The following is a description of a gene set: Human Gene Set: GSE37301_MULTIPOTENT_PROGENITOR_VS_GRAN_MONO_PROGENITOR_UP studied in species Homo sapiens Expression profiling of Rag2-deficient Ets1++ and Rag2-deficient Ets1-- mature NK cells and WT bone marrow progenitors, WT T cells, and WT Pro B cells from publication Ramirez K, Chandler KJ, Spaulding C, Zandi S, Sigvardsson M, Graves BJ, Kee BL (PMID 22608498) Genes up-regulated in multipotent progenitors versus granulocyte-monocyte progenitors., and this is the list of marker genes: GLI3, DNTTIP2, PAK3, ZNF574, ZZZ3, CXCL2, TBL2, TPD52 (NCBI Gene Id 7163), GBP7, APOA5, MYD88 (NCBI Gene Id 4615), PRKAB1, CGA, SETDB1, CEBPD, KLF2, MAPKAPK5, FBXL12, TOR3A, RACK1, CDCP1, SNX10, RNASE3, SLC6A8, PSME1, SEMA6B, MYL6B, CCDC86, MTHFD2, FGFR3, SELENOW, NELFA, PSMB8, PDK3, ABRACL, TYR, PKM, ZNF639, CD244, HELB, SYCP3, BET1L, POU3F3, NIPBL, STC1, C16orf89, CTNNA1, IL10RB, MYH4, MAF, CR2, HPX, ADIPOQ, INTS9, GNL3, HMGA2, LRP10, C11orf16, ID1, SRRM1, DAB2, FANCG, COL13A1, NREP, POLA1, MFSD4A, CASP8AP2, MAP4K3, C5AR1, GRINA, GPR12, PRDM5, UBE2S, DDX39B, CYB561, NAMPT, GATA2, NIP7 (nucleolar pre-rRNA processing protein NIP7), TNFRSF1A, IL17RA, NOP58, IRGM, CD14, IFIH1, XDH, PLSCR1, CAMLG, LEPROT, IGLL1, TCIRG1, EXT1 (NCBI Gene Id 3966), IL13RA1, INTS6, ADAM9, KRT34, BZW2, ROM1, PTPN1, JAK2, RSAD2, IDNK (IDNK gluconokinase), HOXC6, IFIT2, PKDCC, KLRD1, AZIN1, CDH3, CD2BP2, PGM2, PRSS58, NGDN, SLC1A5, HOXC5, IL7R (NCBI Gene Id 3575), C5orf15, RFX1 (regulatory factor X1), ABCB10, COL4A1, FXYD7, ACTN2, TUT7, SENP3, LMO4, MVP, FOXO4, KRR1, KL, H3-5, SAMD4B, MYBPH, MX2, ISG15, CMPK2, WDR26, LMNB2, MC3R, GNA14, MSH2, MAP2K1, STAT1, CD34, SLC6A1, BLK, KRTAP8-1, SHISA5, ALK, NUB1, PPAN, PDCD7, PGAP4, ISG20 (interferon stimulated exonuclease gene 20), MDN1, EFNA1, PML, UTP3, F2RL2, EIF3F, SAMHD1 (SAM and HD domain containing deoxynucleoside triphosphate triphosphohydrolase 1), NKX2-2 (NCBI Gene Id 4821), BMP2K, USP18, PHC2, PI4K2A, RAB3IP, UCK2, ANXA2, PTPN2, REEP1, ACKR3, TRDMT1, SCN10A, EPS8, LY75 (NCBI Gene Id 4065), SSX2IP, EXTL3, MPL, PLAGL1, ANPEP, GEMIN5, BCL3, HLA-G, SOD2, PRG3, IFNA1, OTUD5 (OTU deubiquitinase 5), ATP7A, IL7, GLG1, PNPT1, MEIS1, TSC22D1, ZNFX1, NEUROD4, FABP9, ARMC10, KCNU1, MYO10, MYL11, KAT2A (NCBI Gene Id 2648)